Given this list of marker genes P2RY12, BRCC3, WIPF1, C12orf56, FOXC2, VCAN, GUCD1, KCNA2, KCNK6, CTSC, CHADL, PHGDH, HTR6, SLC25A34, AIRE, PAK6, OAS2, AP5Z1, PTGIR, ZNF784, FKBP8, PLA2G4A, TEF, TM7SF3, HSD11B1, AFF2, SLC30A8 (solute carrier family 30 member 8), TMCO5A, CHD3, RARRES1, FBP1, CPNE9, CDKL4, SLIT2 (slit guidance ligand 2), NKG7, SLC7A8, MMP14, CHSY1, SIX4 (NCBI Gene Id 51804), TNFRSF1A, TBX21, ITPKA, PMCH, ACBD3, LMNTD2 (NCBI Gene Id 256329), IFNG, HSDL2, RDH5 (retinol dehydrogenase 5), DAW1, PBX3, MRS2, IFIH1, SMAD2, SRFBP1, STARD6, IL15RA, HAS3, TSPYL5, TMEM154, CCT6B, TMTC2, NMNAT2, IRAK2, OPN1SW, CKMT1B, AGFG2, HOPX, H2BC3, TNNI1, DIO3OS, ARHGAP21, RAP2A, NCCRP1, MED7, CCND3, FAP, UHMK1, CTSD, DRD3, MED12L, C1orf56, KCNK4, LRP4, GPR171, TUBE1, MPP1, HEPACAM2, WDFY3, CNTNAP4, IFNGR1, PARP9, RGS1, TRPC4AP, RBMS2, RUNX3, DDR1, IFIT2, PKD2, NPLOC4, WDR86, VTCN1, SPATA2L, LBX1, ADAM18, PLCG2, SLAMF7, ZNHIT6, MCOLN2, GRIN2D, DLGAP1, TMEM175, SLC12A4 (NCBI Gene Id 6560), BMX, FGG (NCBI Gene Id 2266), SRP19, OIT3, OTOA, TGM3, SLFN5, MATN2, SYNRG, AGT, TIMM9, ANKIB1, FFAR4, HERC6, GPRIN1, PMFBP1, SLC6A18, C6orf141, SCN11A, CAMK1G, HES3, N4BP2L2, XRN2, KIF23, POC5, PUM3, C19orf67, CLEC4D, AURKB, SLC1A7, NKPD1, TMEM125, H2AX, SRRD, SMYD5, POLA1 (DNA polymerase alpha 1, catalytic subunit), TMEM200A, ARL14, FOXP2, TREML2, RRAS2, STK32A, AICDA, CNTROB, USF2, ABCB9, SLC7A5, CCL1, TRIM26, EXOC3L1, CHAD, DDX25, B3GNT9, TSKU, INHBA, GP1BA, NEUROG3, B4GALT1, SYNE3, ARF1, NAB2, PLEK, C12orf75, NTN4, TMEM129, MXD1, SLFNL1, APBB1, STK10, NIPA2, FAM184A, MRPL38, GLOD5, MACC1 (NCBI Gene Id 346389), INTS14, KLRC1, PPP2R1B, UBL5, TSFM, MRGBP, SPESP1, CMAS, FES, NUDT7, CDKN1A, CREB1, PAX7, ABI3, here is a description of the gene set: Discrimination between self vs. non-self and adequate response to infection and tissue damage are fundamental functions of the immune system. The rapid and global spread of known and emerging viruses is a testament that the timely detection of viral pathogens that reproduce within host cells, presents a formidable challenge to the immune system. To gain access to a proper reproductive niche, many pathogens travel via the host vasculature and therefore become exposed to humoral factors of the innate immune system. Although a cascade of coagulation factors plays a fundamental role in host defense for “living fossils” such as horseshoe crabs (Xiphosurida spp), the role of the coagulation system in activation of innate responses to pathogens in higher organisms remains unclear. When human type C adenovirus (HAdv) enters the circulation, 240 copies of coagulation factor X (FX) bind to the virus particle with picomolar affinity. Here, using molecular dynamics flexible fitting (MDFF) and high resolution cryo-electron microscopy (cryo-EM), we defined the interface between the HAdv5 hexon protein and FX at pseudo-atomic level. Based on this structural data, we introduced a single amino acid substitution, T424A, in the hexon that completely abrogated FX interaction with the virus. In vivo genome-wide transcriptional profiling revealed that FX-binding-ablated virus failed to activate a distinct network of the early response genes, whose expression depends on transcription factor NFKB1. Deconvolution of the signaling network responsible for early gene activation showed that the FX-HAdv complex triggers MyD88/TRIF/TRAF6 signaling upon activation of toll-like receptor 4 (TLR4) that serves as a principal sensor of FX-virus complex in vivo. Our study implicates host factor “decoration” of the virus as a mechanism to trigger innate immune sensor that respond to a misplacement of coagulation FX from the blood into intracellular macrophage compartments upon virus entry into the cell. Our results further the mounting evidence of evolutionary conservation between the coagulation system and innate immunity. from publication Doronin K, Flatt JW, Di Paolo NC, Khare R, Kalyuzhniy O, Acchione M, Sumida JP, Ohto U, Shimizu T, Akashi-Takamura S, Miyake K, MacDonald JW, Bammler TK, Beyer RP, Farin FM, Stewart PL, Shayakhmetov DM (PMID 23019612) Human Gene Set: GSE36078_WT_VS_IL1R_KO_LUNG_DC_UP Genes up-regulated in Lung dendritic cell from untreated wildtype mice versus Lung dendritic cell from untreated IL-1R mice. studied in species Homo sapiens